Given this list of marker genes MCTP2, PPP1R15B (protein phosphatase 1 regulatory subunit 15B), SEC23B (NCBI Gene Id 980), TROAP, ZNF562, PLEKHA3, ETV5, MBD4, PRKAR2A, RSBN1, FOXI1 (NCBI Gene Id 2299), BNC1, DLGAP1, FBXO33, ABCC4, ZNF212, FBLN5, MICU3, TSHZ3, MTERF1, RBM23, KCTD9, HSD17B6, PSMA3, NAPG, AUTS2, MDM4, ACTR1A, SPRED2, CCNE2, SCN8A, TFAP2A, UHRF2, RAB6A, LDB2, NAA16, CPSF6, SIGLEC6, TOX3, TAX1BP1, NCOA4, ADRA1D, SMPX, PRKAB2, UBL4A (ubiquitin like 4A), USP27X, DFFA, CHRNA3, PGPEP1L, RBBP4, ACO2, DGKI, HDHD2, FCN3, SCNN1A, RBL1, PHEX, here is a description of the gene set: Human Gene Set: MIR664B_5P from publication Chen Y, Wang X (PMID 31504780) species: Homo sapiens Genes predicted to be targets of miRBase v22 microRNA hsa-miR-664b-5p in miRDB v6.0 with MirTarget v4 prediction scores > 80 (high confidence targets).